The following is a description of a gene set: Human Gene Set: GOBP_CD4_POSITIVE_ALPHA_BETA_T_CELL_ACTIVATION The change in morphology and behavior of a CD4-positive, alpha-beta T cell resulting from exposure to a mitogen, cytokine, chemokine, cellular ligand, or an antigen for which it is specific. species: Homo sapiens, and this is the list of marker genes: CCL19, RUNX3, FUT7, NKG7, MTOR, PRKCZ, NKX2-3, HMGB1, CDH26, IL23A, LGALS9C, CTSL, BRD4, IL6ST, STAT4, TGFBR2, JUNB, MEN1, PDP2 (pyruvate dehydrogenase phosphatase catalytic subunit 2), TARM1, NDFIP1, BRD2, ENTPD7, KMT2A, NCKAP1L, TCIRG1, TNFSF4, GPR183, EP300, CD3E, IL6R, IL2, JAK1, TNFSF18, LY9, JAK3, ICOSLG, BCL6, IL18, LEF1, CBLB, HLA-DRB1, CD28, VSIR, CD69, KCNK18, BATF, IL23R, LOXL3, TBK1, ICOS, PLA2G2D, RC3H2, SEMA4A, IL12B, ZFPM1, IL27, IL12RB1, OPA1, ZBTB7B, LGALS9B, NLRP3, CEBPB, SOCS1, CD55, SMAD7, SASH3, SH3RF1, CD81, CD274, XCL1, LGALS1, CARD11, CD83, FOXP3, STAT5A, ATP7A, RUNX1, ASCL2, PRKCQ, SPN, TMEM98, FOXP1, IRF4, ANXA1, SOCS3, HLA-DRA, IL18R1, BCL3, TOX, GPR65, MYB, RORA, AGER, MIR21, PTGER4, LGALS9, IL2RA, STOML2, BRAF, SLAMF6, STAT6, SOCS5, NFKBID, MALT1, IL21, ZC3H12A (NCBI Gene Id 80149), HLX, ITCH, KLHL25, CBFB, RC3H1, IL4R, RSAD2, ARG2, ARMC5, SHB, STAT3, NFKBIZ, IL6, TBX21, CD160, CD86, PIK3R1, RORC, GATA3, TWSG1, RELB (RELB proto-oncogene, NF-kB subunit), RARA, HLA-DRB3, IFNG, RIPK2, CD80, IL2RG, CRACR2A